The following is a description of a gene set: Mutation-activated GNAS to ACTH-cortisol signaling pathway. Pathway ID: N00321. Pathway type: Variant. Pathway class: nt06360 Cushing syndrome. studied in species Homo sapiens Human Gene Set: KEGG_MEDICUS_VARIANT_MUTATION_ACTIVATED_GNAS_TO_ACTH_CORTISOL_SIGNALING_PATHWAY Pathway Definition from KEGG: GNAS* -> ADCY -> cAMP -> PKA -> (NR5A1,NR4A1,SP1,PBX1,CREB) => (STAR,CYP11B1) -> Cortisol, and this is the list of marker genes: PRKACA, CREB3L3, NR4A1, CREB3L1, ATF2, ADCY9, ADCY7, GNAS, ADCY8, CREB5, ATF4, ADCY4, ADCY5, CREB3L2, ADCY2, SP1, ADCY3, CYP11B1, STAR, ATF6B, PRKACG, CREB3, CREB1, ADCY6, NR5A1, CREB3L4, PRKACB, ADCY1, PBX1